The following is a description of a gene set: Human Gene Set: GOCC_ELONGATOR_HOLOENZYME_COMPLEX A heterohexameric protein complex composed two discrete heterotrimeric subcomplexes that is involved in modification of wobble nucleosides in tRNA. species: Homo sapiens, and this is the list of marker genes: ELP1, ELP2, ELP3, ELP4, ELP5 (elongator acetyltransferase complex subunit 5), ELP6